The following is a description of a gene set: Mouse Gene Set: GOBP_EXTRATHYMIC_T_CELL_DIFFERENTIATION species: Mus musculus The process in which a precursor cell type acquires the specialized features of a T cell via a differentiation pathway independent of the thymus., and this is the list of marker genes: Zfp683, Il15, Btnl6 (NCBI Gene Id 81498), Prdm1, Btnl1